The following is a description of a gene set: Mouse Gene Set: chr17E5 species: Mus musculus, and this is the list of marker genes: Gm22593, Gm19145, Gm1976, Gm9416, Gm23102, Gm20939, Mettl4, Gm19815, Gm6741 (NCBI Gene Id 640421), Gm4719, Gm9665, Gm41654, Fshr, Gm6764, Gm10308, Gm20491, 2700099C18Rik, Gm19853, Gm41653, Gm9411, Gm24244, Gm9410, 4930480K15Rik, 4933400B14Rik, Gm10493 (NCBI Gene Id 623954), Gm21018, Adcyap1, Gm6751, Amd-ps7, Nrxn1, Kpna2rt, Gm15403